The following is a description of a gene set: Human Gene Set: SA_FAS_SIGNALING The TNF-type receptor Fas induces apoptosis on ligand binding. studied in species Homo sapiens, and this is the list of marker genes: CFLAR, CASP3, PDE6D, FASLG, FAS, BCL2, CFL1, CASP8, S100A10